The following is a description of a gene set: species: Mus musculus Mouse Gene Set: REACTOME_HYALURONAN_BIOSYNTHESIS_AND_EXPORT Hyaluronan biosynthesis and export, and this is the list of marker genes: Has3, Cemip, Has2, Abcc5, Has1